The following is a description of a gene set: Genes down-regulated in UB27 cells (osteosarcoma) at 8 hr after inducing the expression of a mutant form of WT1. The Wilms' tumor suppressor gene (WT1) encodes a zinc finger transcription factor that is vital during development of several organs including metanephric kidneys. Despite the critical regulatory role of WT1, the pathways and mechanisms by which WT1 orchestrates development remain elusive. To identify WT1 target genes, we performed a genome-wide expression profiling analysis in cells expressing inducible WT1. We identified a number of direct WT1 target genes, including the epidermal growth factor (EGF)-family ligands epiregulin and HB-EGF, the chemokine CX3CL1, and the transcription factors SLUG and JUNB. The target genes were validated using quantitative reverse transcriptase-polymerase chain reaction, small interfering RNA knockdowns, chromatin immunoprecipitation, and luciferase reporter analyses. Immunohistochemistry of fetal kidneys confirmed that a number of the WT1 target genes had overlapping expression patterns with the highly restricted spatiotemporal expression of WT1. Finally, using an in vitro embryonic kidney culture assay, we found that the addition of recombinant epiregulin, amphiregulin, CX3CL1, and interleukin-11 significantly enhanced ureteric bud branching morphogenesis. Our genome-wide screen implicates WT1 in the transcriptional regulation of the EGF-family of growth factors as well as the CX3CL1 chemokine during nephrogenesis. from publication Kim HS, Kim MS, Hancock AL, Harper JC, Park JY, Poy G, Perantoni AO, Cam M, Malik K, Lee SB (PMID 17430890) Human Gene Set: KIM_WT1_TARGETS_8HR_DN species: Homo sapiens, and this is the list of marker genes: CITED2, ACKR3, DLST, MSR1, CASP1, KLRG1, SPTLC2, GGCX, GATD3 (glutamine amidotransferase class 1 domain containing 3), LILRA2, BAZ2B, ITGA2B, PAPOLA, HIGD2A, AP1S1, ZNF514, BAD, TESMIN, CR1, ELK4, KRT3, CENPF, CHP1, KYNU, BRDT, SPINK1, HUS1, GPRC5A, APBB2, FST, SRRT, FCF1 (NCBI Gene Id 51077), ST6GALNAC5, NNMT, NDUFA1, NEAT1 (NCBI Gene Id 283131), ITPK1, DACT1, ERF, BOLA2, STK17A, ANP32A, MIR3648-1, NELFA, RPL10, TBCB, FJX1 (NCBI Gene Id 24147), RHOT2, CCN2, AMIGO2, LAX1, LOX, PPFIA3, RHOBTB3, MAB21L1, YY1AP1, ACBD3, SIX6, TGFB2, PIMREG, NDUFS6, RGS17, LSM4 (LSM4 homolog, U6 small nuclear RNA and mRNA degradation associated), LSM14B, RPS9, EHMT2, FZD2, ZDHHC11, TUFT1, LRRC19, RET, SMAD4, MANF, NFYA, MSH5, MGAM2, MID1, SEMG1, EDF1, ATXN7, TMEM14B, RBM12B-AS1, OGFR, TMPO, F2RL1, ZNF302, APOF, GP2, REXO2, ZAP70, RAB29, HMGCS1, RGS7, AURKB, PLAC8, ASPH, ID1, SEMA3C, CSNK1G3, IL18, CD24P2, PCCA, ULK2, AGPS, CDKN1C, PSPH, WNT8B, SIVA1, NFATC3, PGAP1, IGF2BP3 (insulin like growth factor 2 mRNA binding protein 3), TSSK2, PCLO, EXTL3 (exostosin like glycosyltransferase 3), HNRNPR, SLC11A2, SPOCK2, HPS4, NRG1, MIA (MIA SH3 domain containing), PLK2, GTF2F2, ASIP, TSR3, SOD2, CALD1